The following is a description of a gene set: studied in species Homo sapiens Human Gene Set: chr11p14, and this is the list of marker genes: MIR8087, HSP90AA2P, LINC02755 (NCBI Gene Id 105376605), RN7SKP158, METTL15, LINC02699, CCDC34, LINC02718, MUC15, LINC02726 (NCBI Gene Id 105376593), LINC01616, MPPED2, SLC17A6-DT, LINC00678, BDNF-AS, BBOX1-AS1, SVIP, SLC5A12, RPL12P30, LINC02686, ENSG00000296353, RN7SL240P, LINC02546, ENSG00000294117, LINC02758, RPL7AP58, LINC01495 (NCBI Gene Id 102723378), ARL14EP-DT, RPL36AP40, KCNA4, FIBIN, KIF18A, RNA5SP338, SLC17A6, MIR8054, EEF1A1P47, LINC02742, BDNF, RNU6-783P, LINC03096, ENSG00000255357, ANO3-AS1, ARL14EP, OR2BH1P, WIZP1, THAP12P4, MIR8068, RNA5SP339, BBOX1, LIN7C, CCDC179, LUZP2, CBX3P1 (NCBI Gene Id 159770), MIR610, MPPED2-AS1, LGR4-AS1, HNRNPRP2 (NCBI Gene Id 100421354), FSHB, GAS2, LGR4, ATP5MGP8, FANCF, ANO3